Given this list of marker genes NCK2, GHITM, FPR1, SLC15A3, CACNA1D, GALNT10, CALCRL, NRP2, STX6, RFFL, MTDH, ZC3H15, LMO4, DENND5A, CHM, GOLGA3, CCL5, TBC1D1, CPEB4, ARL14EP (NCBI Gene Id 120534), KIF5C, PKP4, MPC1, ME1, SLC6A13, ALPK2, ITGA5, NFKB1 (NCBI Gene Id 4790), TRA2A, TTC1, MOB4, SERINC1, BIRC3, ELL2, SLC39A14, GPD2, PLAGL2, PPFIBP2 (PPFIA binding protein 2), NLRP3, NPPC, MAGOHB, SLC1A2, CRBN, TUT7, GRAMD2B, IFITM2, MTHFR, ISG20, THEMIS2, IGF2BP2, AFTPH, FDFT1, NAT1, RRAGD, JAG1, TBC1D13, CREB1, TJP1 (tight junction protein 1), MSANTD3, CPTP, RTP4, MAPKAPK2, TGM2, MAFK, HELZ2, PENK, TANK, ABCA1, TOR1AIP2, NUPR1, ETS2, TNFSF10, SYNPO2, KAT2B (lysine acetyltransferase 2B), PLCD1, SATB2, IFI35 (NCBI Gene Id 3430), PPP2R2A, PSMD12, ADAM17, TRIM26, CWC22, PTK2B (NCBI Gene Id 5748), SGCB, GCA, SLC27A2, UBA7, FNDC3A, REL, IL15, COCH, DUSP14, RNF19A, RPS6KA2, WNK1, STXBP1, TFG, TNFSF8, ALCAM, CSF1, MITD1, MYLK, FBXW11, CCDC198 (coiled-coil domain containing 198), TOP1, APBB1IP, COL4A6, TAP1, HBEGF, RAB1A, PPP1R15B, ARHGEF3, MKI67, CRY1, PHC2, CCNJ, CD72, DNAJC1, IL23A, F11R, LIMS4, ATP10A, NOS2, ICAM1, AIM2, EYA3, TOX4 (TOX high mobility group box family member 4), ENPP4, DPF2, PALS1, IRGM, ECE1, B4GALT4, UPP1, LAP3, RDH11, AFF1, POU3F1, PTGES, DLL4, IKBKB, NNAT, FAM53C, DSCAML1, BCL9 (NCBI Gene Id 607), GFI1, PILRA, YTHDF1, GBP7, SLC25A37, PDGFRB, RNF19B, ASB13, SERPINC1, SHFL, ENO2, MTMR14, IKBKE, FCGR3A, TOR3A, DUSP16, RMDN3, TENT2, SCML4, ITGAV, EDN1, CD247, RTN1, RAB10, TSLP, GPR85, IL36A, F10, SYNE2, GABARAPL2, ANXA1, ZNF436, HLA-G, ASF1A (NCBI Gene Id 25842), COP1, ADGRE1, STARD5, IL18, EIF1AY, CP (NCBI Gene Id 1356), KCTD10, LY96, VNN2 (NCBI Gene Id 8875), REPS1, RAB3IP, COL10A1, RBL1, SLC28A2, LTA, MTF2, XYLT2, RFK, JAK2, E2F8, CAMLG, here is a description of the gene set: from publication Amit I, Garber M, Chevrier N, Leite AP, Donner Y, Eisenhaure T, Guttman M, Grenier JK, Li W, Zuk O, Schubert LA, Birditt B, Shay T, Goren A, Zhang X, Smith Z, Deering R, McDonald RC, Cabili M, Bernstein BE, Rinn JL, Meissner A, Root DE, Hacohen N, Regev A (PMID 19729616) mouse primary BMDCs were stimulated with tlr ligands and gene expression changes were profiled on Affymetrix arrays Genes down-regulated in comparison of dendritic cells (DC) stimulated with CpG DNA (TLR9 agonist) at 0.5 h versus those stimulated with CpG DNA (TLR9 agonist) at 4 h. studied in species Homo sapiens Human Gene Set: GSE17721_0.5H_VS_4H_CPG_BMDC_DN